The following is a description of a gene set: studied in species Homo sapiens SARS-CoV-2 and COVID-19 pathway Human Gene Set: WP_SARSCOV2_AND_COVID19_PATHWAY, and this is the list of marker genes: SLC6A19, CTSL, TMPRSS4, FURIN, ACAT1, TMPRSS2, NRP1, ACE2, TLR7, SCARB1